The following is a description of a gene set: Any process that increases the frequency, rate or extent of the platelet-derived growth factor receptor signaling pathway. studied in species Homo sapiens Human Gene Set: GOBP_POSITIVE_REGULATION_OF_PLATELET_DERIVED_GROWTH_FACTOR_RECEPTOR_SIGNALING_PATHWAY, and this is the list of marker genes: HIP1R, IL1R1, SRC (NCBI Gene Id 6714), F7, MIR296, F3, HIP1, IL1B